The following is a description of a gene set: The aggregation, arrangement and bonding together of a set of components to form a telomerase holoenzyme complex. Mouse Gene Set: GOBP_TELOMERASE_HOLOENZYME_COMPLEX_ASSEMBLY studied in species Mus musculus, and this is the list of marker genes: Nvl, Hsp90aa1, Hsp90ab1, Naf1, Atm, Atr, Dkc1, Ptges3, Ptges3-ps